Given this list of marker genes CBX5, ZCCHC9, DNAJA2, ADRB2, NRAS, ARK2C, PDPR, GOLT1B, CEP135, RANBP2, FAM135A, SEMA4G, OSBPL3, PBX2, ZNF784, CNTRL, CCND2, ATL2, DCUN1D2 (defective in cullin neddylation 1 domain containing 2), RDX, MARS2, GFM2, OPA3, RASGRP1, ABL2, SOCS4, RFX6, MAP3K9, ACVR2A, E2F2, PLXND1, MBD2, OSMR, PPP1R16B, GATM, ZNF644, PDE12, ZBTB8B, CPEB3, LPGAT1, ACSL6, ACTA1, AP1S1, RGS6, SLC2A12 (NCBI Gene Id 155191), DCAF15, CLCN5, MRS2, EDN1, KCNJ11, IGF1R, LIPT2, CCL7, LEPROTL1, LBR, TGFBR1, RIMOC1, GDF6, POGZ, YPEL2, PTPRD, XKR8, GALNT1, PBX3, COL4A2, PRPF38B, DDTL, FRAS1, GXYLT1, NEK3, LRIG2, HAND1, ARG2, TMEM65, STARD9, SCN4B, SUB1, COL1A2, CEP120 (centrosomal protein 120), INTS6L, HOXA1, FNIP1, PLA2G3, ADRB3, PLPP6, MMS22L, NME6, UGCG, ENTPD7, CEMIP2, EIF4G2 (eukaryotic translation initiation factor 4 gamma 2), MAPK6, SLC35D2, IGDCC4, HECTD2, COIL, STIMATE, MIB1, BACH1, PARP8, MAP3K1, PCDH19, BEND4, ARID3B, PRTG (NCBI Gene Id 650816), ZNF512B, ASAP1, CRTAM, ZBP1, WNT9B, DDX19B, ZNF710, DNAJC1 (NCBI Gene Id 95528), EDEM3, CLDN12, DHX57, WDR37, SALL4, IGF2BP1, PBX1, CD164, ELF4, KCTD17, IGF2BP3, SLC20A1, CLP1, NGF, UTRN, LIMD2, ABCC5, AGAP1, RBFOX2, SRGAP1, SLC22A23, STARD13, NPHP3, TRIM71, SLF2, IGDCC3, PXDN, MEIS2, KLF8, ZNF322, SIGLEC14, HDLBP, TRANK1, PLEKHO1, DLC1, GJC1, PLXNC1, NAP1L1, KDM3A, C15orf39, FNDC3B (fibronectin type III domain containing 3B), EPHA4, COL3A1, DNA2, GALC, YOD1, BEGAIN, SENP5, SNX30, ERCC4, FZD4, MED8, SLC31A2, AEN, GAN, MAP4K3, CASP3, DTX2, C19orf47 (chromosome 19 open reading frame 47), SFMBT1, AMOT, EEA1, MYCN, MEF2C, CPA4, RUFY3, ATP8B4, XK, RALB (NCBI Gene Id 5899), PEG10, PABIR1, TMEM121B, E2F6, XYLT1, CCNJ, ATP2A2, NYNRIN, BSN, PAPPA (pappalysin 1), SLC5A9, PALD1, GABBR2 (gamma-aminobutyric acid type B receptor subunit 2), ZBTB5, SRD5A3, EEF2K (eukaryotic elongation factor 2 kinase), FGD6, THOC2, SIGLEC5, PCGF3, CERT1, APBB3, DUSP22, HOOK1, ARMT1, PIK3IP1, ANKRA2, AGO4, ZFYVE26, CDKN1A, XRN1, NIPAL4, DNAAF9, GPCPD1, ONECUT2, UHRF2, RNF20, SLC25A27, FIGNL2, IMPG2, IKZF2, GNG5, SPRYD4, ACVR1C, SKIL, HIF1AN, CLDN16, TMPRSS2 (transmembrane serine protease 2), PLPP5, SALL3, ADAMTS15, FBXL12 (F-box and leucine rich repeat protein 12), IRS2, ELP1, SMIM3, SEMA4C, PDP2, STX3, PLEKHG6, MTDH, COL4A1, MTUS1, TECPR2, SLC5A6, HIP1, TMEM234, TMC7, RSPO2, FNDC3A, LINGO1, VAV3, CNOT6L, ESR2, KCNC2, GCNT4, LIN28B (NCBI Gene Id 389421), MAPK8, SMARCAD1, FRMD4B, FAXC, CD59, BZW1 (basic leucine zipper and W2 domains 1), KCTD21, RGS16, STK40, CPEB1, STRBP, PLEKHA8 (NCBI Gene Id 84725), HAS2, DDI2, LRIG3, TMOD2, VCF1 (NCBI Gene Id 84923), SESTD1, HMGA2, ZNF516, VIRMA, BIN3, POLL, ZNF275, LIPH, KLF9, DMD, INSR, ITGB3, COL5A2, NR6A1 (NCBI Gene Id 2649), FASLG, LIN28A, COL4A6, AHCTF1, ZNF583, C14orf28, FIGN, LAMP2, ARID3A, PARPBP (NCBI Gene Id 55010), AMT, ERCC6, ZNF280B, DUSP1, TGFBR3, PRSS22, PEX11B, KLHL31, USP44, USP38, CERCAM, FNIP2, ZSWIM5, CDC25A, B3GNT7, CDC34, NPEPL1, NME4, GPR26 (NCBI Gene Id 2849), TSPEAR, TNFSF9, DTX4, RAB8B, COL27A1, SCD, TAF9B, SMC1A, ZNF689, CADM2, STARD3NL, ADAMTS8, HDX, E2F5, DVL3, PTAFR, RAB11FIP4, ERO1A, DPH3, USP24, C8orf58, KIAA1958, KLHDC8B, NHLRC3, KIAA0930, CARNMT1, PPP1R15B, ACER2, SCN11A, GALNT2, GPATCH2, TMPPE, EFHD2, B4GAT1, DDX19A, ABT1, ARL5A, AKAP6, GNPTAB, SLC38A9, HSPA14, PLAGL2, TBKBP1, ARHGAP28, SNX16, DIP2A, IL13, GAS7, DLST, PXT1, SLC10A7 (solute carrier family 10 member 7), POLR3D, IQCB1, THRSP, PRLR, PIGA, ATOSB, TRIM67, HOXD1, GRPEL2, NKAPD1, ENTREP2, SDK1, CPEB2, FGF11, RICTOR, TSEN34, SLC16A9, TTLL4, POGLUT1, SENP2, CHD4, TMEM167A, ABCB9, MDM4, ARHGEF38, MFSD4A, MASP1, GYG2, TET3, GTF2I, PGRMC1, HIC2, IGF2BP2, FZD3, DPP6, here is a description of the gene set: from publication Chen Y, Wang X (PMID 31504780) Human Gene Set: LET_7I_5P studied in species Homo sapiens Genes predicted to be targets of miRBase v22 microRNA hsa-let-7i-5p in miRDB v6.0 with MirTarget v4 prediction scores > 80 (high confidence targets).